Given this list of marker genes CAMK1D, PLCG2, CAMK4, CAMK2G, CALM3, PLCG1, CAMK2B, CALM2, PDGFRA, CALM1, CAMK1, CAMK2D, CAMK2A, CAMK1G (calcium/calmodulin dependent protein kinase IG), here is a description of the gene set: Amplified PDGFR to PLCG-CAMK signaling pathway. Pathway ID: N00029. Pathway type: Variant. Pathway class: nt06273 Glioma. Pathway Definition from KEGG: PDGFR* -> PLCG -> IP3 -> Ca2+ -> CALM == CAMK Human Gene Set: KEGG_MEDICUS_VARIANT_AMPLIFIED_PDGFR_TO_PLCG_CAMK_SIGNALING_PATHWAY species: Homo sapiens